The following is a description of a gene set: Human Gene Set: HP_ABNORMALITY_OF_SKELETAL_MATURATION Abnormality of skeletal maturation The bones of the skeleton undergo a series of characteristic changes in size, shape, and calcification from fetal life until puberty. An abnormality of this process can include delayed or accelerated skeletal maturation, or deviation of some, but not all bones from the expected patterns of maturation. species: Homo sapiens, and this is the list of marker genes: CTBP1, TCF20, SOX3 (SRY-box transcription factor 3), ASXL2, GATA4, ANKRD17, RNU4ATAC, COX4I2, FAM111A, PCNT, KCNJ2, MECP2, KARS1, HUWE1, EVC2, EFEMP1, RRAS2, POLR3H (NCBI Gene Id 91605), PRKACA, FKBP6, SRP54, ITCH, FARSB, WNT5A, GTF2IRD1, CCDC141, ROR2, TONSL (NCBI Gene Id 4796), ANAPC1, GBA1, POU1F1, MALT1, BRD4, PIK3R1, NCF1, MC4R, ALDH18A1, EIF4H (NCBI Gene Id 94573), CPLX1, CYP11B1, BRAF, TBL2, NFE2L2, FSHB, DYNC2LI1, SLC29A3, ANKRD11, B4GALT7, HS6ST1, ROBO3, SMC1A, NGLY1, LGR4, DNAJC21, ERCC5, FOXE1, MT-ATP8, MAP3K7, NDNF, XPA, SPRY4, SMARCD1, SHOC2, TAC3, GPC3, TP53, NUP107, ZSWIM7, XPC, BMP2, KMT2A, PPP1R21, SIN3B, EYA1, SLC10A7, UBR1, BAZ1B, STX1A, RNU12, RFC2, SECISBP2, PPP2R3C, SMPD1, NR2F1, RBBP8, POP1, GPR101 (NCBI Gene Id 83550), ALMS1, SEMA3A, ORC4, RAF1, AIFM1, KISS1, MKRN3 (makorin ring finger protein 3), RMRP, FGD1, ENPP1, PIGT (NCBI Gene Id 94004), APC2, CLIP2, SLC30A7, NR0B1, CAV1, NHLH2 (nescient helix-loop-helix 2), PNPLA6, ATRX, GNAS, GPX4, RRM2B (NCBI Gene Id 50484), GTF2H5, PLK4, KRAS, PROP1, DHX37, TRAF7, TRPV4, DPP6, DCC, CAVIN1, IHH, CYP19A1, DONSON, NSD1, ARID2, RIT1, LIG4, NSD2, CBL, RRAS, COL2A1, FMR1, SOS1, MVK, GNRH1, AGPAT2, EVC, GHSR, ABCC9 (ATP binding cassette subfamily C member 9), INPPL1, ADAMTS17, DNA2, CDC45, MMP13, GNRHR (NCBI Gene Id 2798), PRKACB, CCDC8, TRHR, GTF2IRD2, FOXP2, RNF113A, PRKAR1A, HSPG2, MADD, ERCC4, BNC1, SLC25A24, CDC6, RNF135, SCARB2, MSH4, NIN, CEP152, ELN, RBM28, DUSP6, ITGB6, RECQL4, RAD21, CHST3, TACR3, GLI2, CENPE, METTL27, SMC3, GLI3 (GLI family zinc finger 3), LONP1, NUP85, ERCC3, FGF17, GDF5, DDB2, PROKR2, PPARG, WWOX, NMNAT1, OBSL1, ASCC3, IGF2, INSR, AARS1, EZH2, RNPC3, EXTL3, CSGALNACT1, RSPRY1 (NCBI Gene Id 89970), SBDS, PPOX, UBE3C, LSS, VAMP7, THRB, SMARCC2, ORC1, NPR2, GHRHR, PRKG2, SPRED2, FOXA2, GMNN, BMPR1B, POR, SMARCB1, PPP1R15B, SOX4, LHCGR, STAT5B, CDKN1C, BTK, UFSP2, PDE4D, TAF13, ABCD4, ORC6, LZTR1, CD96, GHR, KISS1R, MSTO1, CANT1, SUZ12, NSUN2, CCBE1, SMARCE1, TBCE, DPF2, ANOS1, DDOST, PAM16, ESR1, ADAMTS10, POLA1, MPLKIP, KCNJ8, SMAD4, ARCN1, BMP15, EED, SLC7A7, TMEM67, MSMO1, ADAMTSL2 (ADAMTS like 2), EXT1, ERCC2, GUSB, BRF1, BSCL2, FGFRL1, FGF8, RASA2, ANTXR1, GPC4, NBAS, LETM1, ACVR1, MCM9, PEX1, CYB5A, HSD17B4, FBN1, IFT57, ARID1B (AT-rich interaction domain 1B), GRB10, ERI1, THRA, PROK2, PSMC3IP (PSMC3 interacting protein), GH1, NR5A1, ACAN, MEN1, IGFALS, H19, PAX1, NAA10, STAT1, ZNF699, TAF6, WDR11, FBXO11, FLRT3, NRAS, TRAIP, PTEN, FEZF1, BUD23, SMARCA4, TRPS1, TET3, CARS1, HDAC8, LEP, ARID1A, LHX4, HMGA2, PIK3C2A, EFL1, IGF1R, B3GAT3, ATR, PDGFRB, LTBP2, HESX1, MBTPS2, GTF2E2, IGF1, CDT1, TMEM270, NSMF, VPS37D, CYP11A1, PCGF2, CUL7, DNAJC30, SPIDR, PTH1R, RPS6KA3, FLNB, SOX11, HRAS, KCNQ1, GJA1, PEX6, SLC35D1, CKAP2L, LPIN2, NELFA, MT-TL1, AGA, GTF2I, LTBP3, FOS, AIP, ZFPM2, EP300, MC2R, SMARCA2, TSHR, CEP57, DVL1 (NCBI Gene Id 348497), XYLT1, PPP1CB, ZFX, NFIX (NCBI Gene Id 4784), WDR4, KCNQ1OT1, CENPT, OTX2, TSHB, SOX10, SOX9, NEU1, TAF4, NIPBL, MAP3K1, PIGG, SLC26A2, PTCH1, MRPS22, RNF13, COX4I1 (NCBI Gene Id 1327), SOS2, FGFR1, SRY, IL17RD (NCBI Gene Id 54756), HSD11B1, CYP17A1, TRH (NCBI Gene Id 7200), MRAS, KIF15, AHSG, CHP1, PTPN11, CREBBP, POU3F4, GET4, LIMK1, PCSK1, H1-4, ZEB2, SRCAP, GLI1 (GLI family zinc finger 1), SIN3A, TBCK, POMC, ATRIP, CTNS, PTDSS1, PAX8, TARS1, CHD7, WT1, SPRTN, DDX6, SOHLH1, FSHR, ALG9, QRICH1, LEPR